The following is a description of a gene set: part of: Plasma lipoprotein clearance LDL (low-density lipoproteins) are complexes of a single molecule of apoprotein B-100 (apoB-100) non-covalently associated with triacylglycerol, free cholesterol, cholesterol esters, and phospholipids.Clearance of LDL from the blood involves binding to LDL receptors associated with coated pits at the cell surface, forming complexes that are internalized and passed via clathrin-coated vesicles to endosomes, where they dissociate. The LDL particles move into lysosomes and are degraded while the LDL receptors are returned to the cell surface. This process occurs in most cell types but is especially prominent in hepatocytes. It plays a major role in returning cholesterol from peripheral tissues to the liver. Reactome Pathway: LDL clearance studied in species Homo sapiens, and this is the list of marker genes: NPC1, NCEH1, LDLRAP1, AP2S1, SOAT2, AP2A1, LDLR, CES3, AP2B1, AP2M1, CLTA, LSR, PCSK9, NPC2, LIPA, APOB, CLTC, SOAT1, AP2A2